Given this list of marker genes CDCP1, ADGRG1, SPATS2L, FUT8, LIPH, KRT86, ITGA2, GPR161, AMTN, CSF1R, CDYL, GSDME (gasdermin E), ELF4, DDX60, BACE2, ZFP91, ADAM19, TRAF3IP2, PDLIM3, MARS1, PDK4, CLDN2 (NCBI Gene Id 9075), SLIT3, WARS1, ITGB3, NTN4, IL1B, IER3, SPOCD1, HMGA1, TAPBPL, MFSD1, LAMB3, ZBTB24, SLC20A1, MOXD1, B4GALT4, TP53I3, HHAT, MTHFD1L, P2RY6, PDE2A, PLAUR, DYNC1LI2, ANKLE2 (ankyrin repeat and LEM domain containing 2), CXCL1, TLR2, GSPT1, BDKRB2, BMF, RBM26, LRP12, RDH10, ADAM23, MYO1D, CD36, EPHB2, IGF2BP3, ODAPH, PHLDA1, TP53BP1, SVIL, ITPR3, PLEKHO1, DOCK6, SH3PXD2B, ANGPTL4 (angiopoietin like 4), TNFRSF21, EREG, NT5E, PLIN2, LARGE1, NPC1, IL15RA, KIFC3, PMEPA1, SKIL, RASA1, IL11, KIAA0930, CYP1B1, TNFAIP8, C15orf48, LPXN, EBI3, IL6, ITGAV, GNPTAB, SLC39A6, EXT1, DUSP5, KLF11, GARS1, LHFPL2, ITGB5, SH2B3, HMGA2, BAZ1A, LRP10, PIP4K2C, SIAH1, ZNF281, CLIC4, here is a description of the gene set: Human hepatocellular carcinoma (HCC) heterogeneity promotes recurrence and therapeutic resistance. We recently have demonstrated that inflammation favors hepatocyte retrodifferentiation into progenitor cells. Here, we identified molecular effectors inducing HCC metabolic reprogramming, chemoresistance and invasiveness of retrodifferentiated stem cells. Spheroid cultures of human HepaRG-progenitors (HepaRG-Spheres), HBG-BC2, HepG2 and HuH7 cells and isolation of side population (SP) from HepaRG cells (HepaRG-SP) were followed by transcriptomics, signaling pathway analysis and evaluation of chemotherapies. Gene expression profiles of HepaRG-SP and HepaRG-Spheres were enriched in signatures related to cancer stem cells, metastasis and recurrence and showed that HepaRG-progenitors can further retrodifferentiate into a more immature state. The transcriptome from these stem cells matched that of proliferative bad outcome HCCs in a cohort of 457 patients. These HCC stem cells highly expressed cytokines triggering retrodifferentiation and displayed high migration/invasion potential. Importantly, they showed changes in mitochondrial activity with reduced membrane potential, low ATP production and high lactate production. These changes were in part related to angiopoietin-like 4 (ANGPTL4)-induced upregulation of pyruvate dehydrogenase kinase 4 (PDK4), an inhibitor of mitochondrial pyruvate dehydrogenase. Interestingly, up-regulation of ANGPTL4 and PDK4 paralleled that of stem cells markers in human HCC specimens. Moreover, the PDK4 inhibitor dichloroacetate reversed chemoresistance to sorafenib or cisplatin in HCC stem cells derived from four HCC cell lines. In conclusion, retrodifferentiated cancer cells develop enhanced invasion and therapeutic resistance through ANGPTL4 and PDK4. Restoration of mitochondrial activity in combination with chemotherapy represents an attractive therapeutic approach in HCCs. Genes up-regulated in the cancer stem HepaRG-sphere vs HepaRG at 10 days of differentiation Human Gene Set: FEKIR_HEPARG_SPHERE_VS_HEPARG_UP from publication Fekir K, Dubois-Pot-Schneider H, Désert R, Daniel Y, Glaise D, Rauch C, Morel F, Fromenty B, Musso O, Cabillic F, Corlu A (PMID 30837223) studied in species Homo sapiens